The following is a description of a gene set: Human Gene Set: GSE1112_HY_CD8AB_VS_HY_CD8AA_THYMOCYTE_RTOC_CULTURE_UP Genes up-regulated in CD8 alphabeta HY thymocyte RTOC culture versus CD8 alphaalpha HY thymocyte RTOC culture. from publication Yamagata T, Mathis D, Benoist C (PMID 15133507) species: Homo sapiens Four independent chip hybridization with RNAs from four independent RTOC cultures., and this is the list of marker genes: RUNX3, APOL6, TPT1-AS1, RAPSN, PELO, DESI1, CKAP2, OR1J2, SLAMF8, UGT2B28, TPMT, FANCB, ANKFN1, APOL1, CCND2, SH3BP5, ERAP2, ATP8B4, TLL1, HLA-DRB1 (major histocompatibility complex, class II, DR beta 1), RALA, DPH3, DYNLT2B, ADAMTS6, WFDC3, ARTN, HLA-DRB6, SLPI, ARHGEF5, MARCO, PNPLA8, MRGPRG-AS1, LINC02297, IRF1, LYNX1, RSAD2, HIVEP3, SPATA6, SECTM1, DPY19L2P3, CARD6, VN1R3, KCNJ6, VCAM1, LGALS3BP, AK8, SMC1B, RTP4, STARD4, CA10, PNP, STARD8, TNFRSF10A, GIMAP8, HLA-DPB1, PTGS2, NDUFA10, NT5C1B, PSMD12, HCAR3 (hydroxycarboxylic acid receptor 3), EREG, SPATS2, RGMB, S100A2, RRM2B, STX3, CLEC5A, POMP, TLNRD1, EPYC, TIPARP, PPIF, PSMB8, XKR6, SERPINI1, USP15, BDNF-AS, NLRC5, CALHM6, SCGB2A2, VPS41, DNAJC18, BANP, PTN, HLA-DPA1, FBXO6, IL36RN, HLA-DRA, BAK1, CSF2, GBP5, STAP2, SLC5A9, LTB4R, IER2, NEK2-DT, HM13, MACROH2A2, CASP1, PSMB9, SCPEP1, LAMTOR3, LLCFC1, ADCY5, SLC31A1, TOX2, BCL7B, IQGAP2, SERPINB8, PLAAT4, HLA-DQA1, MGAM, WARS1, UGT2B4, MMP25, THUMPD2, PDP1, KHNYN, NT5C3A, CD59, NWD2, UPB1, HINT1, SLC2A3, SLC22A15, PNMA8B, NXT2, LINC00870 (NCBI Gene Id 201617), SIPA1L1, EIF1, UBE2L6, LTBP1, MDGA1, DYDC1, SNX9, POU3F4, NR1H4, PSME2, NT5C1A, SLC44A5, GBP2, KCNK5, RAB18, RNF149, LAT2, HBBP1, MYOF, STX1A, PDZK1, STAT2, POLB, THBS4, SFXN2 (NCBI Gene Id 94082), CREM (cAMP responsive element modulator), IL12RB1, OTOGL, PLEKHO1, TCHH, MYO1E, TNF, PARP14, TAP2, SUB1, GBP1, LINC02245, POC1B, OAF, ZNF267, BCL2A1, B2M (NCBI Gene Id 567), PHLDA2, NME9, TMEM207, RGS17, CDON, MAP3K14-AS1 (NCBI Gene Id 100133991), GREM2, SAMD9L, TMEM35A (NCBI Gene Id 59353), BTN3A1, KRBOX1, BRF2, DUXAP10, EAF1, ZNF276, STAT1, CASP4LP, DNAJB11, STING1, HLA-DQB1, FAM161A, GBP4, CD74